Given this list of marker genes Cyp4b1, Cyp2d22, Cyp3a13, Cyp3a11, Cyp4f39, Cyp4a29, Cyp4a10, Cyp4a31, Cyp2u1, Cyp3a25, Cyp3a16, Cyp4a12a, Cyp3a44, Cyp4f18 (cytochrome P450, family 4, subfamily f, polypeptide 18), Cyp3a57, Cyp4f40, Cyp3a41b, Cyp3a41a, Cyp4f15, Cyp4a30b, here is a description of the gene set: electronically inferred by orthology from the curated human pathway Reactome Pathway: Miscellaneous substrates This event has been computationally inferred from an event that has been demonstrated in another species.<p>The inference is based on the homology mapping from PANTHER. Briefly, reactions for which all involved PhysicalEntities (in input, output and catalyst) have a mapped orthologue/paralogue (for complexes at least 75% of components must have a mapping) are inferred to the other species. part of: Cytochrome P450 - arranged by substrate type species: Mus musculus